The following is a description of a gene set: species: Homo sapiens Neighborhood of CDK2 cyclin-dependent kinase 2 in the MORF expression compendium Neighborhood of CDK2 Human Gene Set: MORF_CDK2, and this is the list of marker genes: EBP, SLC4A2, HNRNPA2B1, ETF1, KXD1 (KxDL motif containing 1), GPAA1, PABPN1, ESYT1, U2AF1, BUB3, CLTC, KHDRBS1, DNAJC8, PKMYT1, GTF2A2, LRPPRC, TCEA1, HDAC2, PCMT1, PSMD2, RUVBL2, DDB1, POLR2C, YWHAQ, HNRNPU, CDK2, MCM2, ZNF131, XPO6, TCOF1, HNRNPAB, SNRPA, GNB1, PSMB7, NAE1, NONO, PRPF8, CS, NUP188, DEK, NUDT1, AFG3L2, TEX261, SRRM1, DYRK2, PWP1, HNRNPD, NUP62, SCARB1, EIF3I (eukaryotic translation initiation factor 3 subunit I), SUMO2, POLR2A, CTDNEP1, ILF2, SSB, PRKDC, FUS, SEPTIN7, XPO7, CAD, SNRNP200, XRCC5, RPA2, COPS6 (COP9 signalosome subunit 6), ARL6IP1, ATXN2L, CCT4, H2AZ1 (H2A.Z variant histone 1), DOCK3, AATF, SSRP1, STARD7